Given this list of marker genes Txnip, Meis2, Ppp1r3c, Nfib, Col3a1, here is a description of the gene set: Genes down-regulated in MEF cells (embryonic fibroblast) upon stimulation with TGFB1 for 1 h. Mouse Gene Set: PLASARI_TGFB1_TARGETS_1HR_DN studied in species Mus musculus Transforming growth factor beta (TGF-beta) and platelet-derived growth factor A (PDGFAlpha) play a central role in tissue morphogenesis and repair, but their interplay remain poorly understood. The nuclear factor I C (NFI-C) transcription factor has been implicated in TGF-beta signaling, extracellular matrix deposition, and skin appendage pathologies, but a potential role in skin morphogenesis or healing had not been assessed. To evaluate this possibility, we performed a global gene expression analysis in NFI-C(-/-) and wild-type embryonic primary murine fibroblasts. This indicated that NFI-C acts mostly to repress gene expression in response to TGF-beta1. Misregulated genes were prominently overrepresented by regulators of connective tissue inflammation and repair. In vivo skin healing revealed a faster inflammatory stage and wound closure in NFI-C(-/-) mice. Expression of PDGFA and PDGF-receptor alpha were increased in wounds of NFI-C(-/-) mice, explaining the early recruitment of macrophages and fibroblasts. Differentiation of fibroblasts to contractile myofibroblasts was also elevated, providing a rationale for faster wound closure. Taken together with the role of TGF-beta in myofibroblast differentiation, our results imply a central role of NFI-C in the interplay of the two signaling pathways and in regulation of the progression of tissue regeneration. from publication Plasari G, Calabrese A, Dusserre Y, Gronostajski RM, McNair A, Michalik L, Mermod N (PMID 19752192)